The following is a description of a gene set: from publication Chen Y, Wang X (PMID 31504780) Genes predicted to be targets of miRBase v22 microRNA hsa-miR-185-5p in miRDB v6.0 with MirTarget v4 prediction scores > 80 (high confidence targets). species: Homo sapiens Human Gene Set: MIR185_5P, and this is the list of marker genes: CNOT9, GSTA4, ARF3, FAM135B, NPNT, PNP, ADAM22, GRIN2B, SARNP, WNT1, MTHFS, KLHL29, ATAT1, LPCAT3, ZNF444, SIX2, TUBGCP3 (NCBI Gene Id 10426), LCOR, RERE, PBX2, PCDHA12, TCP1, SIX3, SHISAL1, SUMF2, PLEKHA5, MXRA5, DCX, ADRA1A, ZNF557, XKR5, TPMT, FAM234B, CFAP44, SSTR2, PGLYRP4, ARID1A, GTF3C4, INO80D, SGMS1, BTLA, LYN, RHOA, GNB3 (G protein subunit beta 3), DLG2, DOCK3, EPPK1, PCDHA11, NHLRC2, MLLT11, PCDH9, SPTB, MIER1, ZNF473, USB1, TRIM66, MS4A3, FBXL17, TBC1D5, GJA1, RCC1L, PCDHA4, SPATS2, SMCO4, SLC17A2, PCDHAC2, SLC25A28, FCRL3, ETV3L, DEFA5, CDH4, MAU2, RDX, CEP15, ZNF704, UBXN10, XYLB, MRPS21, NMNAT2, MSI1, ARMC8, NOTCH2, ZNF662 (NCBI Gene Id 389114), PAK6, CASP14, KANK2, FOXP4, CSMD2 (NCBI Gene Id 282565), PHF21A (PHD finger protein 21A), TPD52L1, SYN1, FIGNL2, CSRNP2, FBXO41, TAP2, HOOK3, LDLR, XYLT1, DDX18, USP3, ADH4, GINS1, PCDHA2, RAE1, EMC10, TRPM3, STX6, MAT2A, FZD4, COMMD2, RORA, AFAP1L2, CDC42, RGS8, ATXN1, KCNK9, ENC1, HIC2, SOX5 (SRY-box transcription factor 5), LHX2, FANCD2OS, AGO1, ERCC6, CENPO, NBN, PM20D1, ACACB, RAB35, HDX, RALGAPB, LINC03043, ISG20, SIPA1L1, PXT1, ADGRL1, HOPX, SEL1L3, KIAA1328, HCN4, ST20-MTHFS (NCBI Gene Id 100528021), CARD18, MAB21L2, ELOVL4, PRR5L, POPDC2 (popeye domain containing 2), TBC1D19, PCDHA13, AKAP6, CNTNAP5, YWHAG, RNASEH2B, SIGLEC1 (sialic acid binding Ig like lectin 1), WNT9B, KCNN3, PARP11, USPL1, UBE2H, PCDHAC1, SPATA2, HIPK2, CD209, SSX1, CNTLN, PIM1, GEMIN7 (NCBI Gene Id 79760), FMN1, EXOC6B, PRR23A, RASEF, INTS6, ORC5, PREPL, KPRP, CARF, AKR1C2, CCND2, TMEM139, FAM222B, ZNF236 (zinc finger protein 236), SLC16A2, SDF2 (NCBI Gene Id 6388), TTC28, CEP104, SYNM, PCDH10, MS4A2, MECP2, TMEM165, SLC8A1, B3GAT1, TCF12, SCD, CGN, KLK5, ZNF2, HCCS, AR, SMG7, ADGRB1, SIX1, DCTN3 (dynactin subunit 3), PCDHA9, CPNE6, ANKFY1, CACNG4, KAT6A, RIMOC1, SF1, CXCL9, LRRC32, HP1BP3, PCDHA10, TTBK1, SRGAP2, SLC30A3, PPP1R3B, TSPAN18, TBC1D30, PATZ1, NETO1, EFTUD2, EFCAB2, ABCG4, SNX30, CD300LD-AS1, ZNF586, EPB41L1, JAGN1 (jagunal homolog 1), SH3BP2, FAM163B, RNF20, CDYL2, PHLDB1, CTDNEP1, FOXN4, TRIM58, EIF2AK1, PALM2AKAP2, FAM76A, MTCL2, GPNMB, GPR84, FANCA, LAMP5, RHOT1, SOX13, TOX3, GPX3, BSN (bassoon presynaptic cytomatrix protein), EPHB2, ABCG1, PCDHA5, CCNL2, METTL25B, PCDHA6, SNAP25, NFATC3, CHMP7, PCDHA7, PCDHA3, PMF1, PCDHA8, ULK4, LRIT1 (leucine rich repeat, Ig-like and transmembrane domains 1), TMEM150C, MRPL34, PCDHA1, WDCP, UBE2D4, PRKAR2A, YIPF1, TAF5L, RIC8B, NR1D1, ATP1A3, HDAC5, CNTD1, MON1B, HIF1AN, ANKRD45, DYNLL2, FAM151B, KCNJ5, GATAD1, NCAN, BCAT1, SREBF2, GJA5, ATP6V1F, ZCCHC12 (zinc finger CCHC-type containing 12), CA10 (carbonic anhydrase 10), SORL1, OPRM1, BASP1